Given this list of marker genes NVL, CDKN2A, UTP25, GLUL, WRN, MCRS1, RRS1, HEATR1, NOL8, PINX1, NOP53, BYSL, POLR1A, CACNB4, RPF2, TERT, NPM1, RRP7A, NMD3, RAN, here is a description of the gene set: studied in species Homo sapiens Human Gene Set: GOBP_PROTEIN_LOCALIZATION_TO_NUCLEOLUS A process in which a protein is transported to, or maintained in, a location within a nucleolus.